Given this list of marker genes CDKN1A, ZFHX3, TGFB1, RUNX3, SMAD4, SMAD3, TP53, here is a description of the gene set: part of: Transcriptional regulation by RUNX3 RUNX3 contributes to the upregulation of the CDKN1A (p21) gene transcription in response to TGF-beta (TGFB1) signaling. RUNX3 binds to SMAD3 and SMAD4, and cooperates with the activated SMAD3:SMAD4 complex in transactivation of CDKN1A. Runx3 knockout mice exhibit decreased sensitivity to TGF-beta and develop gastric epithelial hyperplasia. In response to TGF-beta signaling, the CBFB:RUNX3 complex binds to the tumor suppressor ZFHX3 (ATBF1) and, through an unknown mechanism, this complex positively regulates the CDKN1A transcription.<br>In addition, RUNX3 may act as a TP53 co-factor, stimulating TP53-mediated transcription of target genes, including CDKN1A (p21). species: Homo sapiens Reactome Pathway: RUNX3 regulates CDKN1A transcription